Given this list of marker genes MT-ND4, MT-TR, MT-RNR1, MT-TF, MT-TG, MT-ND4L, MT-ND3, here is a description of the gene set: species: Homo sapiens Genes containing one or more binding sites for (RARB) in their promoter regions (TSS -1000,+100 bp) as identified by GTRD version 20.06 ChIP-seq harmonization. from publication Yevshin I, Sharipov R, Kolmykov S, Kondrakhin Y, Kolpakov F (PMID 30445619) Human Gene Set: RARB_TARGET_GENES